Given this list of marker genes C5orf46, CMKLR2 (chemerin chemokine-like receptor 2), PRDM1, DLGAP4, HOXA3, IDH1, MAP4K5, TCP11L2, HSP90B1, TMEM88, CTDSPL2, CPNE1, FBXO40, FOSL2, CHN1, AKT2, BRAF, GRB7, SEPTIN4, VAX1, AGPAT4, ZFP28, C17orf58, VPS45, AMY2B, ESRRG, RUNX1T1, SLITRK6, CALD1, C2orf66, OTX2, SPDEF, ETV1, PCF11 (NCBI Gene Id 51585), EFNA5, NOG, SUPT3H, GPBP1, ULK1 (unc-51 like autophagy activating kinase 1), HTN1, RGS8, RP1L1, LINC00305, ZC3H10, CCN6, ITGB6, LRR1, TCERG1L, ICAM5, RASSF6, SGK3, MAFF, LGI1, CITED2, LMO4, NEUROD2, ZIC5, NSG2, ZNF516-DT, BRMS1, KDM6A, LAMB3, TIAM1, ARID4A, ATXN7L1, EFEMP1, BPIFA1, PIP4K2A, GSX1, TBC1D19, LMO3, VCPKMT, CCDC116, MRPS18B, SIM1, TRERF1, MCM7, CNPPD1, GFRA1, BCL11A, NAV3, TMEM94, ATOH8, POU2F1, FGB, CTAGE4, HOXC5, NIPBL, PLEKHA5, GCG, CDKN1A, RBFOX1, GNAO1, SDK2, RAB3IP, BNC2, ARTN, LHX5, CD68, NUB1, ZBTB20, TRPC4, CRCT1, ZBTB40, CELF6, OTP, NOVA1, HOXA2, AKT1S1, CNNM3, KLHL24, ANKRD28, LHX9, TNFRSF19, MITF, TMEM131L (NCBI Gene Id 23240), HOXA10, KCNJ13, ANGPT2, RETREG2, C1orf87, FOXP2, TFAP4, QRICH1, ZMYND8, PELI2, PCSK1, OTUD7B, PRPF39, LRP2, NEDD4 (NEDD4 E3 ubiquitin protein ligase), MEIS2, CDK6, TXNDC12, HOXA11, CDKN1C, SQSTM1, HERPUD1, HOXA13, TGFB1, TMEM222, PRICKLE2, TCF15, PAGR1, LUC7L2, RESF1, AP4M1, PPP1CB, MYL1, POU3F3, TBC1D17, ZHX2, DCN, PPP1R12A, SLC38A3, EIF4EBP2, TBX4, ARHGAP30, C1orf116, RPN2, KIAA0586, BCLAF3, DVL2, SCRN3, TRAF3, SKIDA1, LCP2, ZNF362, RBM39, MAML3, GRIK3, PHOX2B, EGR2, ZIC2, PALS2, TSHZ3, DTNA, LRP3, NTN1, NEUROG1, MKX, SCG2, LRAT, NSD3, NHSL2, PAK1 (NCBI Gene Id 5058), DENND2C, LRTM1, FAP, FAM53C, BCL11B, PURA, ID2, FGF9, PPP2R2B, TIAL1, XPO7, FSTL1, SH3GL3, NSRP1, CREBL2, TGFB3, TBXAS1, PHF21B, PAPPA, SEL1L3, HOXA4, HOXC8, TIMM9, BCL9, LEF1, CADM1, ARID1B, NTRK3, TRIM8, KCTD4, CCDC71L, CELF4, DENND4C (DENN domain containing 4C), PRR34, PPP1R10 (NCBI Gene Id 5514), ZMAT4, PHLPP1, MEX3B, GSE1 (NCBI Gene Id 23199), ATP5MC2, ZEB2, C1QTNF6, EYA1, ETV4, THRA, TSPYL2, IMPDH1, HOXA9, DCX, TCF7L2, IRAG1, NRG1, CCDC112, SESTD1, POGZ, ZNF521 (zinc finger protein 521), MRGPRF, HMCN1, TTR, BAMBI, BUB3, MARCHF6, KCNJ5, PTCHD1, SLC35A2, SLITRK2, JADE2, MMP11, EMP3, KRTAP13-2, HOXC12, MBNL2, here is a description of the gene set: studied in species Homo sapiens Human Gene Set: FREAC3_01 Genes having at least one occurrence of the motif NNNNNGTAAATAAACA in the regions spanning 4 kb centered on their transcription starting sites. This matches the FOXC1 transcription factor binding site V$FREAC3_01 (v7.4 TRANSFAC).